The following is a description of a gene set: Human CD14 positive monocytes were purified from healthy volunteers’ blood and cultured in vitro for 4, 12, 24, 72 hours. While culturing, macrophages were activated alternatively with interleukin-4 (IL-4 100 ng/ml) or classically with interferon-gamma (IFNg 100 ng/ml)+tumor necrosis factor (TNF 50 ng/ml) or left without activation. Simultaneously, macrophages were also treated with vehicle (DMSO:ethanol) or 1mM synthetic PPARg agonist, Rosiglitazone. We used Affymetrix microarrays (U133Plus 2.0) to analyze activation and PPARg-induced gene expression changes. studied in species Homo sapiens from publication Szanto A, Balint BL, Nagy ZS, Barta E, Dezso B, Pap A, Szeles L, Poliska S, Oros M, Evans RM, Barak Y, Schwabe J, Nagy L (PMID 21093321) Genes down-regulated in monocytes (12h) versus macrophages (12h) treated with IFNG, TNF and rosiglitazone. Human Gene Set: GSE16385_MONOCYTE_VS_12H_ROSIGLITAZONE_IFNG_TNF_TREATED_MACROPHAGE_DN, and this is the list of marker genes: PHACTR2, NFIL3, UBE2J1, FTL, RAMP3 (NCBI Gene Id 10268), PDK3, PPP2CA, NDUFB5, LEO1, NOTCH3, ZC3H14, ZNF518B, BID, DAD1, NRP1, ZNF827 (zinc finger protein 827), NSMCE4A, ARHGAP31, GPATCH2L, CPSF2, FGFBP3, RRP15, CARD6, FBXO21, ZPR1, SLC46A3, SLC9A9 (NCBI Gene Id 339579), CHAMP1, BEND3, B2M, EIF2B5, CD5, TNK2, NAV2, RTP4, POLR2F, RPS6KA6, STK4, GNPDA1, RAB19, SERTAD4, CECR2, CNTNAP2, STAT1, NOLC1, PPP3CA, P3H4, DNMT3A, MMGT1, ZMYND8, SPRING1 (NCBI Gene Id 79794), PTPN22, IRAK3, TUBA4A, AKAP12, CTXN1, AKAP1, ALDH18A1, GRAMD2B, MRPL11 (mitochondrial ribosomal protein L11), SMAD7, SDHC, BTF3, EVL, PABPC4, TSHZ1, SLC25A6, SLC35B1, C1orf21, SPATA13, SS18, PPM1D, EEIG1, MAPRE2 (microtubule associated protein RP/EB family member 2), SLC25A51, ERC1, ODC1, TXNL4B, TLE1, E2F1, RIPOR2, PPP1R2P1, CD34, TRIM26, RNF149, HNRNPA0, ABCC1, TOMM7, GSR, IER5, CHIC2, G3BP1 (NCBI Gene Id 10146), L3MBTL3, LITAF, SMAD3, NRBF2, TMEM248, TOR3A, NUBP2 (NUBP iron-sulfur cluster assembly factor 2, cytosolic), MAP2K6, KLF2, SRSF12, BPNT1, DNAJB2, LRRC8D (leucine rich repeat containing 8 VRAC subunit D), PLOD2, PGM1, MGAT2, P2RY12, BORCS5, PDZD11, GET3, PRKCH, CARMIL1, TRMT44, IFIH1, ETF1, FBXO45, CMPK1, IGF2BP3, EHD4, BMP7, TENT5C, WDR18, COP1, GAK, TLE4, TES, RHOA, GNB1, ELK4, LUZP1, SEC13, SLAIN1, ATP5MF, MYBL1, NDUFB7 (NADH:ubiquinone oxidoreductase subunit B7), TPD52L2, NCOA7, AIG1, LYSMD2, FBLN2 (fibulin 2), PPP4R2, EHD3, NSUN2, TBL1X, UBE2T, EEA1, SCAMP1, SDAD1, MYO7A, ELL2, ST8SIA1, SUCLG1, RNPEP, RTN4 (NCBI Gene Id 57142), TSPYL4, ZDHHC9, ZFP36L2, YTHDF2, ZNF652, SUPT4H1, EGLN3 (egl-9 family hypoxia inducible factor 3), CCDC43, DDX21, NDFIP1, AMPD1, TSPAN31, DNAJB11, COPB2, PSMC5, SIAH1, FBL, SLC22A2, TRMT6, MIEF2, CTDP1, PGD, POLR2M, YBX3, TWNK, B4GALNT1, PAK1, CRYBG1 (NCBI Gene Id 6763), PPAT, PMEPA1, GARS1, THAP12, EMC6, AKIRIN1, ISY1, SH3GL3, MID1, MRPL54, TSC22D3, ZSCAN20, ASH2L, COIL, MYO18A, TSR1